The following is a description of a gene set: Mouse Gene Set: GOBP_CELLULAR_RESPONSE_TO_PROSTAGLANDIN_STIMULUS Any process that results in a change in state or activity of a cell (in terms of movement, secretion, enzyme production, gene expression, etc.) as a result of a prostagladin stimulus. species: Mus musculus, and this is the list of marker genes: Ptger2, Ptgfr, Prkaa2, Ptgdr, Adcy6, P2ry6, Ptger4, Acaca, P2ry4, Prkaa1, Akt1, Akr1c18, Tnfsf4, Akap8, Prkce, Pax6, Tnc, Gnas, Sfrp1